The following is a description of a gene set: species: Homo sapiens Human Gene Set: HP_HYPERPLASIA_OF_THE_MAXILLA Abnormally increased dimension of the maxilla, especially relative to the mandible, resulting in a malocclusion or malalignment between the upper and lower teeth or in anterior positioning of the nasal base, increased convexity of the face, increased nasolabial angle, or increased width (transverse dimension of the maxilla. Hyperplasia of the maxilla, and this is the list of marker genes: WDR26, HBB, FHL1, SOBP (sine oculis binding protein homolog), SIN3A (NCBI Gene Id 25942), ZNF668, ZBTB11, AP2M1, ESCO2, PIK3CA, SOX5